The following is a description of a gene set: species: Mus musculus Activation of BH3-only proteins Mouse Gene Set: REACTOME_ACTIVATION_OF_BH3_ONLY_PROTEINS, and this is the list of marker genes: Dynll1, Pmaip1, Ywhab, Bad (BCL2-associated agonist of cell death), Bid, Sfn, Ywhag, Ywhae, Ywhaz, Ppp3r1 (protein phosphatase 3, regulatory subunit B, alpha isoform (calcineurin B, type I)), Mapk8, Bcl2l11 (NCBI Gene Id 76339), Ppp3cc, Bmf, Bcl2, Ywhaq, Ywhah (NCBI Gene Id 22629), Dynll2